Given this list of marker genes RNASEH2B (ribonuclease H2 subunit B), KCNQ2, COL1A1, RPS6KA3, RNU7-1, RTEL1, RNASEH2C, ATP11A, MUC5B, FXN, LSM11, IFIH1, TCF4, KCNQ3, SFTPA2, DPP9, STN1, COL5A1, TERT, COL5A2, TREX1, AGXT, PARN, PAX3, ELP1, COQ4 (NCBI Gene Id 51117), SFTPC (surfactant protein C), FAM13A, ABCA3, ADAR, SEPTIN9, FUCA1, ETHE1, SFTPA1, RNASEH2A, SAMHD1 (SAM and HD domain containing deoxynucleoside triphosphate triphosphohydrolase 1), TERC, MVK, DSP, here is a description of the gene set: species: Homo sapiens Peripheral cyanosis Human Gene Set: HP_PERIPHERAL_CYANOSIS Bluish discoloration of the distal extremities in the absence of cold temperature or stress. Peripheral cyanosis can involve hands, fingertips, or toes, and sometimes circumoral and periorbital areas. Mucous membranes are generally not involved.